The following is a description of a gene set: Generalized abnormality of skin Human Gene Set: HP_GENERALIZED_ABNORMALITY_OF_SKIN species: Homo sapiens An abnormality of the skin that is not localized to any one particular region., and this is the list of marker genes: ARPC5, SPRED2, EDN3, ATP1A2 (NCBI Gene Id 93186), PAX3, SLC30A10 (solute carrier family 30 member 10), EPAS1, RORB, NKX2-6, ENG, ALDOB, POU2AF1, HS3ST6, SLC2A2 (solute carrier family 2 member 2), ERCC1, ABCB11, JUP, TP63, MMP23B, ARX, GTF2H5, CENPE, EOGT, LMNB2, PLXND1, RAB27A, DNAJC30, MED12, PWRN1, SMC3 (structural maintenance of chromosomes 3), TBX19, HBA2, BRCC3, NAA10, PYCR1, GNB2, ZBTB16, FTO, HPGD, IL17RA, PSMC3, ADAMTSL2, KYNU, ADAMTS13, PLOD1, TFAM (NCBI Gene Id 8033), PEX5, KMT2E (lysine methyltransferase 2E (inactive)), THSD4 (NCBI Gene Id 79875), KMT2D, SLC25A20, ADAM17, TMC6, SPTLC1, PFKM, NCF4, MYH11, DOK7, PAX8, BLOC1S5, IKZF1, GP9 (glycoprotein IX platelet), NDUFS4 (NCBI Gene Id 4724), SLC5A5, MYO5B, PXK, POGLUT1, SOX5, PIK3R1, G6PC3, LIG4, FOSL2, GLMN, UNC45A, TSPAN12, CFTR, DDX6, ALG6 (NCBI Gene Id 94752), DSE, DEPDC5, SDHA, HYOU1, RHOH, FANCD2, PEX3, PGM3, KNG1, FDFT1, POLG, VPS53 (NCBI Gene Id 55275), GUCY1A1, CYBB, BMP2, COX7B, KCNQ2, MT-TW, CBL, TERT, HERC2, SLC51B, ETFB, EGFR, PRSS2, ETHE1, POLH, SMARCA2, PIGY, RRAS2 (NCBI Gene Id 22800), IRF5, PSENEN (NCBI Gene Id 94939), TINF2, HIRA, COL12A1, ABCD3, SF3B4, BCOR, SCO2, PTF1A, NF1, NRAS, ZNF699, GATA6, MAGEL2, ICOS, PCNT, SPTLC2, SMAD4, ITGA2B, SEC61A1, PRKCZ, ELMO2, PSMG2, ABCB4, CEP104, B3GALT6, GLUL, P2RY12, CD81, ALOX12B, SPP1, SYNGAP1, SLC29A3 (solute carrier family 29 member 3), PRKG1, CARS1, PPARG, SNAP25, STIM1, FLT4, SLC39A13, TGFB3, GALK1, MUC5B (NCBI Gene Id 727897), ERCC5, PPOX, F2, CASP10, HCK (HCK proto-oncogene, Src family tyrosine kinase), HBA1, ABCB6, HSPG2, UBA2, HFE, STUB1, COL1A1, PCNA, FLI1, ETFDH, YARS1, IL12A, DNA2, POLE, KCNN4, HPS6, NECTIN1, NLRP1, SEMA4D, VPS37D (VPS37D subunit of ESCRT-I), COG5, RBM10, CREB3L1, MT-ND4L, SMC1A, BMPR1A, CDKN1B, CACNA1A, MT-CO3, GP1BA, KRT14, DSG4, SP110, NBN, TBX1, MPL, COL5A2, ERCC8, LAMB3, KRT18, PRTN3 (NCBI Gene Id 5657), IARS1, SLC44A1, FASLG, FBLN5, AK9, INSR, GABRD, ERCC2, NHP2, RNASEH2C, C4B, ATP6AP1, RNASEH2A, TNFRSF1A, DGUOK, MT-CYB, TMEM270, SAMHD1, TNXB, RABL3, HLA-DPA1, KANSL1, TERC (telomerase RNA component), NKX2-5, CFH, GJB3, SLC5A6, CYBC1, STAT5B, AKT1, FBN1, ATP6V1B2, PMVK (phosphomevalonate kinase), DOCK6, PRDM16, SOS1, RBM28, CYP27B1, MT-TH, PEPD, PEX16, ALOXE3, KLHL7, PRKAR1A, MASP1, CAVIN1, SLC6A19, TLR7, RET, PTPN22, TFAP2A, SFTPA1, CD28, CLIP2, NABP1, EIF2AK4 (NCBI Gene Id 440275), FGFR2, ATP6V1E1, EPHB2, CDIN1, KREMEN1 (NCBI Gene Id 83999), F13A1, TGM5, WRN, PPP1R15B, ZNF408, CTSA, GTF2IRD1, HOXA11, ATP6AP2 (ATPase H+ transporting accessory protein 2), MYLK, HSD17B10, POLG2, TPI1, FGG (fibrinogen gamma chain), MRE11, MITF, TUFT1, ATR, LYZ, BRCA1, SNORD116-1 (NCBI Gene Id 100033413), LIPA, KIAA0319L, PLCG1, MANBA, KCNQ3, SNORD115-1 (NCBI Gene Id 338433), HCCS, TG, FKBP6, CEP152, IFNG, ANTXR1, LRP1, PLCG2, LMX1B, VAMP1, NHLRC1, PALLD, NTRK1, CLCN7, MAPK1, TBXA2R, IFT56, MAP2K1, PCK1, PDPN (NCBI Gene Id 29912), FUCA1, NOP10, TSC2, CDH11, SKI, DST, FOS, NFKB2, IL12RB1, SOX18, ACVRL1, UFD1, GJB2, CHRNE, CHST14, NAF1, SLC25A24, PEX26, ABL1, TOP3A, NGF, ITGB2, POFUT1, ACADVL, NFIA, GHR, RNASEH2B, IRF2BP2, NEXMIF, HTRA2, CYBA, SDHB, KRT83, IYD, PEX19, SMAD2, ABCC6, CYB5R3, FOXE3, CCR6, LCP2 (NCBI Gene Id 3937), STAT4 (signal transducer and activator of transcription 4), XPC, TULP3, MMACHC, MYO5A, SLC35A1, CIB1, SIK3, USP48, KCTD1, PEX2 (NCBI Gene Id 5828), SLCO1B3, NPC2, TLL1, ALPK1, RECQL, FDPS, GJA1, SLC20A2, SRSF2, DKC1, PCDH19, KRT2, ATP11C, SMAD3, ARMC5, IL36RN, SNX10, ANAPC1, SERPINF2 (NCBI Gene Id 5345), CASZ1 (NCBI Gene Id 654487), TNFSF11, WNT10A, ANK1, UROS, FANCC, F10, TMEM260, CCM2, ATP6V0A2, RIT1, KIF23, PERP, CASR, SFTPB, NAXD, LARP7, ALDH18A1, NPRL2, HPS3, CITED2, CTCF, GLRX5, VIPAS39, NCF2, RFC2, SLC25A1, UVSSA, UBAP2L, ODC1, ALK, LYN, MAOA, CA5A, ZNF469, PIGW, TNFSF15, NLRP12 (NCBI Gene Id 91662), TRMT10A, PKLR, AIP, LORICRIN, MRAS, RAPSN, PDSS1, SERPING1, GPI, NECTIN4, PORCN, FECH, POLA1, CHRND, PEX10, RAB3GAP1, TWIST2, NPRL3, XPR1, HNF1B, SOX9, ADAR, CPOX, MPLKIP, KLLN, C1S, FCGR2A, SYK, FGB, TOR1A, USP18, TP53, FGF23, PEX11B, SBDS, USP8, AKR1D1, DCDC2, NDUFB11, SCN1B, LPL, UBE2L3, ABCC9, RNU7-1, EPM2A, RERE, NKX2-1, LTBP4, ADAMTS19, PDGFRB, IARS2, TNIP1, RAB3GAP2, ANKRD26, CALR, AARS1, HSD3B7, BMPR2, DNASE1L3, STXBP2, LEMD2, LAMC2, IFT122, BLM, GSN, ANTXR2, GFI1B, APC2, GP1BB, ANGPT1, LYST, HDAC8, RPS6KA3, TBX20 (NCBI Gene Id 57057), SLFN14, HOXC13, KITLG, KLK11, ALMS1, RAF1, SCARB2, CAST, GYPC, RAC2, EFEMP1, APOE, SPTBN1, PLK4, MTX2, PEX12, ARPC4, ITGB3, ITGAM, PUS3, PRDM5, TPM4, PDCD1, B4GALT7, ARHGAP31, SLC2A1, DCLRE1B, PWAR1 (Prader Willi/Angelman region RNA 1), FCGR2B, ITGB4, NLRC4, ATL1, MT-CO1, PRKCSH, MT-TL1, COX4I2, WIPF1, XPA, TNFRSF1B, MT-ND1, STX11, PEX1, LIPN (NCBI Gene Id 648165), NCF1, KRAS, RYR1, SLC4A1, ROS1, CTRC, SPTB, SLC25A11, CYB5A, TBL1XR1, HEY2, DPM1, NOD2, EPB42, SLC51A, SETD2, NPC1, MTR, EXPH5, SLC25A13, UGT1A1, FERMT3, FCGR3B, IL7, GCGR, STX1A, POLR3A, KCNAB2, PML, CYLD (NCBI Gene Id 8010), ATP7B, AKT3, FAM13A, ELP1, SPIB, PARN, GNPTAB, NFKBIA, COL5A1, PGAP3, ADRA2A, RNF213, SDHD, CPA1, NEU1, TNFRSF13C, CDH3, ENPP1, ORAI1, ELOVL4, SLURP1, SLC5A7, TRMU, C1QB, MT-TQ, LBR, BANK1, SCN4A, DUOXA2, DSP, CCN2, ETV6, WRAP53, PRRT2, NUP214, HBB, GALE, CHD2 (chromodomain helicase DNA binding protein 2), NUMA1, IFIH1, SKIC3, CCDC115, CFHR3, PIGV, EMILIN1, GLA, DPAGT1, MMP1, SDHAF2, THBS2, MT-CO2, CBLB, ATP1A3, COL17A1, FLNA, F9, PMM2, AXIN2, COQ4, CSTA, ZMPSTE24, MYORG, ELN, KRT10, PIGL, GIMAP5, LMNA, IKBKG, CHRNB1, PIK3CA, MYD88, KIF1B, TGM1, EPOR (NCBI Gene Id 2057), TRAF3IP2, NLRP3, SYT2, DHFR, LHX3, DLL4, EVC, PROP1, TMC8, NFKB1, DTNBP1, SOS2, PRF1, SEC63, PNKP, SPRTN, C4A, COG4, JMJD1C, PKD2, XRCC4, ALAS2, SEPTIN9, F7, DLST, KIF12, GRIK2, ALDH2 (aldehyde dehydrogenase 2 family member), RBBP8, EPB41, TAF6, NSD1, FOCAD, TGFB2, EDA, SDHC, PROC, KCNJ6, IPO8, TRAIP, MDH2, SERPINA1, SEC24C, ASXL1, LIG1, BRCA2, MVK, PTPN11, PHGDH, SFTPC, C2, EVC2, EDAR, PLG, BRD4, GCLC, BMS1, DDB2, TREX1, CPN1, ARL6IP6 (NCBI Gene Id 151188), CBS, MYOF, IGF1R, LUZP1, DHCR7, GATA2, HLA-B, APOLD1, TBK1, PEX14, CHAT, TNFSF12, GPR35, TGFBR1, ITGA2, SREBF1, MMEL1, UNC13D, RASA1, GJB4, RASA2, ATRIP, MAX, ALDOA, SLC10A1, NPAP1, CD46, SCN10A, PDGFB, MCFD2, ARL13B, GORAB, OCLN, FANCA, NR3C1, TRPV3, SPTA1, NIPBL, CSTB, FGA, TXNDC15 (thioredoxin domain containing 15), COL1A2, GPNMB, FANCE, ATRX, TNFSF4, PSAT1, CDKN2A, BAAT, MS4A1 (membrane spanning 4-domains A1), SLC18A3, C1R, RARA, SEC23B, GNE, UROD, SETX, EIF2AK3, MMP21, HLA-DRB1 (major histocompatibility complex, class II, DR beta 1), BSCL2, TPO, ATP11A, PLIN1, ARVCF, TRPV6, FYB1, NSUN2, KRIT1, TGFB1, RTEL1, RAD21, NDP, IFT43, DNASE1, CLTRN, DNMT3A, NDUFS2, ATP2C1, GH1, MRPS2, GALT, SLCO1B1, ADA2, SPINK5, HPS4, TNPO3, HESX1, FKBP14, RNU4ATAC (RNA, U4atac small nuclear), CTLA4, CYP27A1, CR2, COG8, VHL, BLK (BLK proto-oncogene, Src family tyrosine kinase), MUSK, FERMT1, TFR2, ZIC3, ARPC1B, PLEC, MT-ND5, GTPBP3, NR1H4, RHAG, IL18BP, MT-ND6, TRPM4, FGFR1, SASH1, CLPX, EPHB4 (EPH receptor B4), ADAMTS2, KDM1A, HNF4A, ETS1, PRKACA, TSHR, IGHG1, GABRG2, RNF168, BUD23, MTAP, SFTPA2, GNAQ, CTSB, MYH6, EXOSC2, MFAP5, SCN2A, ATP7A, PDE11A, DBR1, LAMA3, POU1F1, SLC39A4, MT-TS2, EDARADD, SLC6A1, GTF2IRD2, ERCC3, BLOC1S3, DDR2, DUOX2, STAT3, PKHD1, GLB1, USP53, STXBP1, FH, GBA1 (glucosylceramidase beta 1), ACD, MEN1, TARS1 (threonyl-tRNA synthetase 1), FOXP3, LHX4, BAZ1B, LRP4, COG7, RNF113A, CLEC7A, PRPS1, RHD (NCBI Gene Id 6007), PGAP2, RPA1, GATA4, DDX11, HMGCL, ACTC1, SERPINE1, JAK2, SPEN, PIGO, F8, GJB6, LIFR, PLAU, HELLPAR, TALDO1, H4C3, SCN8A, SPOP, SMPD1, MT-TF, FXN, TYR, SCN1A, TSC1, CARMIL2, IL10, IL17F, PIGA, ATP6V1A, STN1, CDAN1, HLA-DPB1, LZTR1, GALM, CDH23, ABCA3, HLA-DQB1, RUNX1, RASGRP2, JAG1, NBAS, FIP1L1, AGPAT2, LOX, GP6, SLC1A3, PRKAG2, CAV1, FRG1, FZD4, KRT1, ZEB2, ATL3, COL13A1, AP2M1, TSHB, AGRN, PIEZO1, IER3IP1, SLC16A2, TET2, CFI, GGCX, BTNL2, RRAS, ALDH3A2, POT1, AMACR, MT-ND4, PTEN, MT-ND2, APOA1, RINT1, IRAK1, CTNNB1, COMT, GJA8, F5, CYP7B1, STING1, PLOD3, MKRN3, EDNRB, ADGRE2, MDM2, IL17RC, STAG1, GCSH, DPP9, SAMD9, CD19, HBG2, TTI1, COL3A1, RBPJ, CFHR1, ACTA2, PTDSS1, ERCC4, PRICKLE1, FOXE1, HK1, CTC1, SH2B3, JAZF1, NOTCH1, MEFV, GDF2, NSDHL, XPNPEP2, MPV17, SULT2B1, RIN2, ITGA3, GNAS, UBE4B, USB1, GNA11, PROS1, MLXIPL, WAS, SOX10, ZFYVE19, GABRA1, WDR35, HEATR3, PTPRJ, TBL2, TRHR, ACP5, LSM11, HPS1, TMEM127, VWF, SLC27A4, CHRNA1, MYH7, USF3, ETFA, MVD, PARS2, SLC17A9, LIMK1, TYMS, PEX6, AQP5, PTPN3, SCN11A, MAT2A, TCF4, ALG8, CLDN1, SMARCAD1, FAS, AGXT, SLC26A4, GNA14 (G protein subunit alpha 14), MECP2, DIAPH1, METTL27, NAGA, DSTYK, ERCC6L2, AP1S1, ARID1B, CD109, GTF2E2, GJA5, IL2RG, PEX13, POLD1, ERCC6, PLD1, JAM2, HPS5, SNAI2, TCIRG1, NFIX, AEBP1, BRAF, MBTPS2, HR, DEF6, FGFR3, PSMB8, PALB2, CAPNS1, GATA1, BGN, MT-ATP6, PRSS1, PRKACG, F13B, ATP8B1, SLC34A2, SLC25A3, MYO9A, SPINK1, NUP85 (NCBI Gene Id 83705), NBEAL2, PKP1, TGFBR2, NPM1, KCNK9, FCGR2C, MAP2K2, EIF4H, KIT, SUPT16H, LMAN1, SLC37A4, RREB1, TNFAIP3, G6PD, VPS33B, GTF2I, AGA, LRP5, VEGFC, ATM, CASK, BANF1, H4C5, MST1, COL7A1, KDSR, SCN9A, SLC2A10, PDCD10, KRT5, ABCC2, MYH9, DZIP1L, RHCE, TNFRSF13B, F12, RECQL4